Given this list of marker genes MTERF1, here is a description of the gene set: Transcription of the heavy (H)-strand of mitochondrial DNA (mtDNA) involves two overlapping transcription units (Montoyaet al.,1982; Montoya et al., 1983). The first unit starts right upstream of the tRNAPhe gene and spans the tRNAPhe, rRNA 12S, rRNA 16S and tRNAVal genes (initiation site IH1). The other starts about 100 bp further downstream (initiation site IH2), at the boundary between tRNAPhe and rRNA12S genes, and produces a single polycistronic RNA that encompasses almost the entire length of the H-strand. The ribosomal transcription unit is transcribed at a much higher rate compared to the other transcription unit and control of its expression is exerted both at the level of initiation and termination. A central role in the control of termination has been attributed to the mitochondrial transcription termination factor (mTERF), a 39-kDa protein that binds to a 28-base pair region of mtDNA located within the tRNALeu(UUR) gene, at a position immediately downstream of the rRNA 16S gene (Fernandez-Silva et al.,1997; Kruse et al., 1989). Reactome Pathway: Mitochondrial transcription termination part of: Transcription from mitochondrial promoters studied in species Homo sapiens